The following is a description of a gene set: Mouse Gene Set: GOBP_NEUTROPHIL_DEGRANULATION The regulated exocytosis of secretory granules containing preformed mediators such as proteases, lipases, and inflammatory mediators by a neutrophil. species: Mus musculus, and this is the list of marker genes: Lypd11, Abr, Pram1 (PML-RAR alpha-regulated adaptor molecule 1), Lypd10 (Ly6/PLAUR domain containing 10), Spi1, Itgb2, Myo1f, Cd177, Stx11, Bcr, Itgam, Syk, Itgb2l, Ptafr, Anxa3, Pikfyve, Stxbp3